The following is a description of a gene set: This event has been computationally inferred from an event that has been demonstrated in another species.<p>The inference is based on the homology mapping from PANTHER. Briefly, reactions for which all involved PhysicalEntities (in input, output and catalyst) have a mapped orthologue/paralogue (for complexes at least 75% of components must have a mapping) are inferred to the other species. Reactome Pathway: IPs transport between nucleus and cytosol electronically inferred by orthology from the curated human pathway part of: Inositol phosphate metabolism species: Mus musculus, and this is the list of marker genes: Nup205, Nup133, Ndc1, Rae1, Nup93, Seh1l, Nup54, Nup42, Nup155, Aaas (NCBI Gene Id 223921), Nup85, Nup210, Nup58